The following is a description of a gene set: Genes down-regulated in T conv versus induced T reg with non-functional FOXP3. The gene expression profile of peripheral Foxp3+ natural regulatory T cells isolated from Foxp3/EGFP bicistronic mice was compared to that of in vitro-induced regulatory T cells and to CD4+ conventional (Foxp3-) T cells. The role of the regulatory T cell transcription factor Foxp3 in shaping the transcriptosomes of natural and induced regulatory T cells was analyzed using mice expressing a mutant FOXP3-EGFP fusion protein (Foxp3deltaEGFP). We used gene expression microarrays to examine the transcriptional programs of natural and induced regulatory T cells and the function of Foxp3 in organizing the transcriptosomes of the respective cell type studied in species Homo sapiens Human Gene Set: GSE14415_TCONV_VS_FOXP3_KO_INDUCED_TREG_DN from publication Haribhai D, Lin W, Edwards B, Ziegelbauer J, Salzman NH, Carlson MR, Li SH, Simpson PM, Chatila TA, Williams CB (PMID 19265124), and this is the list of marker genes: PRDX3, PDK3, H4C4 (NCBI Gene Id 8360), NCAPG, LAP3, DTL, STARD4, KIF23, PFDN1, BUB1, MRPS18B, DLGAP5, CENPH, TPX2, MTFR2, KIF11, LRRC59, PPP1R8, PLK1, PMF1, PBK, GINS1, NUF2, DDX21, CENPP, PDIA3, ACAA2, CCNA2, TRIP13, SLC35A5 (solute carrier family 35 member A5), RACGAP1, MTMR1, RRAS2, SNRPB, CDCA3, NRM, ARHGAP11A, WDHD1, HCLS1, TACC3, NUDT1, COX5B, MCM2, TFDP1, IFITM1, SPC24, H4C3, AP1S1, FPR1, PPP4C, PTPN6, KNL1 (kinetochore scaffold 1), CDC7, ORC2, CDCA8, MT2A, NCAPG2, CDC25C, COMMD8, ATAD2, TAF1D, PLAC8, ANXA1, LIMK2, VPS26A, E2F8, KPNA2, API5, ZMAT2, JPT2, PSMD14, SMN1, RRM2, RAB27A, BIRC5, H2AC15, PDHX, H2AC4, KIF4A, BZW1, SAP30BP, NAA50, COX7A2 (cytochrome c oxidase subunit 7A2), PIGT, SSR1, NOP2, GATM, CALM1, TCERG1, PRC1, HMGB3, STMN1, SHKBP1, WDR76, GTF2H5, MAD2L1, LANCL2, MCM6, ALDOA, EPSTI1, ANP32E, RRM1, MTHFD2, SHCBP1, SKA1, IRAK3, CBX5, TSPAN2, NCAPD2, TPI1, ERH, SMC2, TPM1, TOMM6, CYRIB, FIGNL1, FKBP2, CNOT9, CAPZA2, CENPS, SNX5, DCTPP1, BRCA1, SNRPA, KNTC1, CDC45, ATAD5, BUB1B, THYN1, RBM8A (RNA binding motif protein 8A), CDK1, ATP5F1B, KLHDC10, H4C6, MCM3, SAE1, CENPA (centromere protein A), SEPHS2, H2BC14, UHRF1, PSMC1, NOP16, BRIP1, ARHGAP1, GEN1, PLA2G7, KIF15, CHEK1, NUCKS1, PLK4, PPA1, CCNB2, SUCLA2, PA2G4, CEP55, SELENOF, CDK2, RNMT, CORO1A, H2BP2, IGF2BP3, AK2, SYNGR2, SLC31A1, ARL6IP4, PSPH, ITIH5, HASPIN, KIF14, AARSD1, DSCC1, UBR7, PTMS, PSMD8 (NCBI Gene Id 5714), PALS2, AHCY, TIPIN (TIMELESS interacting protein), CLSPN, RFC3, ECE1 (NCBI Gene Id 1889), LMAN1, HMGN2, H1-5, SMAP2, ANAPC5